The following is a description of a gene set: studied in species Homo sapiens Human Gene Set: REACTOME_SENSING_OF_DNA_DOUBLE_STRAND_BREAKS Sensing of DNA Double Strand Breaks, and this is the list of marker genes: KAT5, MRE11, KPNA2, RAD50, NBN, ATM